Given this list of marker genes IL15RA, POLD3, GGCT, MRPL58, SMC2, IRF4, IRGQ, KIF2C, TRNAU1AP, C3orf52, NEK2, ACOX1, BIRC5, MYO5A, ATP5PF, CDC25A, BLTP3B, KIF5B, YWHAH, H2AZ1, TFDP1, ABCC2, MAP3K20, CDKN2A, PELO, G3BP1, CD28, SPRY1, RAD23B, FAM200C, PSMC5, SNRPB2, ESPL1, HMGB3P1, NASP, TNS3, USP13, PRIM1, MANF, OAS3, LAS1L, CNOT7, E2F8, FOSL1, NQO1, CDK7, MRPL13, AURKA, EPB41L2, DBN1, PARP1, KLF9, MED18, GNL3L, SLC7A5, CEP170B, TUBG1, NSD2, GLO1 (NCBI Gene Id 2739, glyoxalase I), BMAL2, BAG2, ARL3, NUP37, PPA1, LRRC8B, RAB11A, FBN1, HMGB3, GTF2A2, POP4, IFNG, CENPA, POLE2, ICAM1, ACOT7 (NCBI Gene Id 11332), IDH3A, NCAPG2, KIF11, METTL8, MCM5, PHGDH, KDM1A, ECI1, SFXN1, NUP155, FABP5, RRM2, MCUR1, CBR3, UBE2C, APBB2, EFCAB2, ERH, HELLS, SCD, EIF4E (NCBI Gene Id 1977), KLK12, ANXA3, CKAP5, GMNN, CLNS1A, DCTN5, GTF2H5, CDC123, RAD51, PCK2, QPRT, LRRC20, TPX2, NME7, SYMPK, DCTN4, HSPE1 (NCBI Gene Id 82869), PSMB5, UBE2W, CYFIP1, FAM3C, RBM47, CD200, TNFRSF4, SNRNP25, TRAC, RECQL4, TMEM70, PLA2G3, PDXK, SLCO4A1, BCAT2, RPP25, SNRPD3, NCAPG, KIF20B, ZFYVE21, PCDH12, SQOR, ANXA5 (annexin A5), NIP7, CCNB2, SNRNP27, GINS2, POLR3K, MSH2, GCLM, USP22, APOD, PXMP2, LRFN4, SMYD5, PSMD12, ENPP2, RRM1, SLC22A1, CCDC47, SKA1, H2AX, HIVEP3, TWSG1, CKS1B, CKS2, HSPA2, HNRNPM, OXCT1, RTRAF, N6AMT1, TCEA2, ATP5MC3, TSPAN13, BLM, SSR3, CCL4, CASP6, GTF2A1, CD1C, CSF2, ADPRM (ADP-ribose/CDP-alcohol diphosphatase, manganese dependent), DEPDC1, TMEM106C, CBS, C1QBP, LRRN3, NEBL, TST, C21orf91, GINS4, ST13, HBEGF, SLC39A14, MIS18BP1, HBS1L, PDCD5, PAICS, KPNA2, PTPRK, STEAP1, CD59, CA6, PMAIP1 (phorbol-12-myristate-13-acetate-induced protein 1), NOL3, SLAMF1, PTTG1, here is a description of the gene set: Genes down-regulated in comparison of NK cells versus Th1 cells. species: Homo sapiens Human Gene Set: GSE3982_NKCELL_VS_TH1_DN In the present study we used Affymetrix oligonucleotide microarrays to produce gene transcription profiles for the major leukocyte types in humans. This comprehensive dataset enabled us to not only establish which genes were expressed in each leukocyte type, but also which genes were expressed in each subset after activation. The used of a comprehensive dataset of gene profiles from all the major human leukocyte subsets enabled a novel and powerful means for identification of genes associated with single leukocyte subsets, or different immune paradigms. from publication Jeffrey KL, Brummer T, Rolph MS, Liu SM, Callejas NA, Grumont RJ, Gillieron C, Mackay F, Grey S, Camps M, Rommel C, Gerondakis SD, Mackay CR (PMID 16474395)